The following is a description of a gene set: species: Homo sapiens Marker genes curated from the annotated cluster as represented in the Descartes Human Gene Expression During Development database. The gene expression program underlying the specification of human cell types is of fundamental interest. The study authors generated human cell atlases of gene expression and chromatin accessibility in fetal tissues. For gene expression, the study authors applied three-level combinatorial indexing to >110 samples representing 15 organs, ultimately profiling ~4 million single cells. The study authors leveraged the literature and other atlases to identify and annotate hundreds of cell types and subtypes, both within and across tissues. Our analyses focused on organ-specific specializations of broadly distributed cell types (such as blood, endothelial, and epithelial), sites of fetal erythropoiesis (which notably included the adrenal gland), and integration with mouse developmental atlases (such as conserved specification of blood cells). These data represent a rich resource for the exploration of in vivo human gene expression in diverse tissues and cell types. from publication Cao J, O'Day DR, Pliner HA, Kingsley PD, Deng M, Daza RM, Zager MA, Aldinger KA, Blecher-Gonen R, Zhang F, Spielmann M, Palis J, Doherty D, Steemers FJ, Glass IA, Trapnell C, Shendure J (PMID 33184181) Human Gene Set: DESCARTES_MAIN_FETAL_OLIGODENDROCYTES, and this is the list of marker genes: PPP2R2B, LINC00609, ADGRB1, RNU6ATAC12P, PDE4B, DBX2-AS1, PCDH15, LINC02294, OPCML, SOX6, MMP16, LHFPL3, RTP5, DLL3, RNF144A, EPN2 (NCBI Gene Id 22905), ENSG00000259072, NIM1K, FYN, OPCML-IT1, LINC02743, LRRC4C, OLIG1, OLIG2, NLGN4Y, NOVA1, PMP2, SCRG1, ENSG00000264449, BCAS1, GLRA3, CHAD, TRIO, LINC02283, KCND2, CSMD1, LINC02488, ZNF365, GRID1, CASK, PLAAT1, NBEAP2, CSPG5, LINC02293, MIR219A2HG, SCN1A, C2orf80, UGT8, FIP1L1, SHC3, ENSG00000234173, NETO1-DT, ENSG00000236494, PDGFRA, CAMSAP2, COL9A1, BRINP3, NOVA1-DT, PCDH9-AS3 (PCDH9 antisense RNA 3), RNU6-581P, BCAN, GPR17, LINC00237, BCAN-AS2